Given this list of marker genes GRM6, P2RX5, PPP3R1, PPP3CB, P2RX1, PPP3CA, PPP3R2, MS4A1, PPP3CC, AKAP5 (NCBI Gene Id 9495), here is a description of the gene set: Any process that activates or increases the frequency, rate or extent of calcium ion import across plasma membrane. studied in species Homo sapiens Human Gene Set: GOBP_POSITIVE_REGULATION_OF_CALCIUM_ION_IMPORT_ACROSS_PLASMA_MEMBRANE